The following is a description of a gene set: Human Gene Set: GSE13411_NAIVE_VS_MEMORY_BCELL_DN from publication Good KL, Avery DT, Tangye SG (PMID 19124732) studied in species Homo sapiens Enhanced secondary Ab responses are a vital component of adaptive immunity, yet little is understood about the intrinsic and extrinsic regulators of naive and memory B cells that results in differences in their responses to Ag. Microarray analysis, together with surface and intracellular phenotyping, revealed that memory B cells have increased expression of members of the TNF receptor, SLAM, B7 and Bcl2 families, as well as the TLR-related molecule CD180 (RP105). Accordingly, memory B cells exhibited enhanced survival, proliferation and Ig secretion, as well as entered division more rapidly than naïve B cells in response to both T-dependent and T-independent stimuli. Furthermore, both IgM and isotype switched memory B cells, but not naïve B cells, co-stimulated CD4+ T cells in vitro through a mechanism dependent on their constitutive expression of CD80 and CD86. This study demonstrates that upregulation of genes involved in activation, co-stimulation and survival provides memory B cells with a unique ability to produce enhanced immune responses and contributes to the maintenance of the memory B cell pool. Genes down-regulated in comparison of naive B cells versus memory B cells., and this is the list of marker genes: IARS1, CEP250, FYN, ZNF780B, EIF4B, EIF2AK1, POU2AF1, NSMAF, TFF2, BDH1, FAM174C, PIP4K2A, TARS2, PELO, PGAM1, XPNPEP1, TARBP1, GRN, TPD52L2, PHLDA2, TBC1D9, ATF4, FOXO3, ZNF91, MRPL12, NME3, DOCK2, BHLHE41, MOB1A, TNIP1, TMEM106C, CPNE1, PIGT, RTN4 (NCBI Gene Id 57142), NCAPD3, LCMT1 (NCBI Gene Id 51628), MTNAP1, UQCR11, UQCRC1, H2AC25 (H2A clustered histone 25), NAP1L4, PAK2, JPT1, CRCT1, REXO4, FKBP1B, H2BC3, SELENOW, HEXB, TRAF3, UST, HOXD12, CERS2, MACROD1, DYNC1H1 (NCBI Gene Id 992), PHKB, SDF2L1, STARD7, MIA3, AFM, SPCS3, METRN, PDIA4, MKRN1, AAR2, VAPB, ATP6V0B, TERF2, CRTAP, DARS1, ECHDC3, HAGH, NIT2, LGALS1, AIM2 (NCBI Gene Id 9447), RBCK1, SMIM8, EDC3, MDH2, MARCKS, JAM3, POLR2J, CCNO, RAF1, EIF2D, PABPC4, BCL2L2, PAX5, MED8, POLR1E, MRPL48, ZDHHC4, JCHAIN, RPL36A, EPRS1, CCR6, CDT1, ZNF343, ATP6V0D1 (ATPase H+ transporting V0 subunit d1), UNC119B, TFDP1, CCNG1, VPS35, NAXD, RBMS1, BTBD7, MLST8, CHP1, EXOSC4, CTSA, MBTPS1, PTPRCAP, PRKCD, GET3, RAC1, PPFIBP2, AP2S1, EHBP1L1, CD27, RPS4X (NCBI Gene Id 6191), HIVEP1, MTMR14 (NCBI Gene Id 64419), LMO4, PABPC1, DNAAF5, CYB5R1, CNPY2, ELMO2, DYNLT1 (dynein light chain Tctex-type 1), ATG2A, CCL5, MRPS34, CBX6, MRPL40, UBE2M (NCBI Gene Id 9040), RUVBL1, CRYBG2, SP140, KLHL12, NARF, MEA1, PGK1, STK39, MRPS7, FKBP14, IL7, RPL39L, EIF3G, PPP1R13B, AIP, DEPDC5 (DEP domain containing 5, GATOR1 subcomplex subunit), SCRN1, FAHD2A, APEH (NCBI Gene Id 95915), COBLL1, GLB1, MAPKAP1, GPI, NEBL, MX2, SRPRA, CSF3R, POLR2E, MSI1, PRSS21, PPM1G, ENOSF1, RNF220, GUK1, PSMF1, GALNT10, RETREG3 (NCBI Gene Id 162427), CCDC25, PPP1R16B, EOLA1, OSBPL3 (NCBI Gene Id 26031), MYO7B, HDAC3, ABCC1, SLC5A12, MTHFD1, PMPCA, DNAH17, ZNF593, ADAR, LDHB, IGFBP3, NEDD4L, BTN3A2, ARL2, SLC35D2, CDK2AP1, GOLGA8A, GSTM2, MSRB1, LHFPL2, REPIN1 (replication initiator 1), GNAS